The following is a description of a gene set: Catalysis of the reaction: acetyl-CoA + histone H3 = CoA + acetyl-histone H3. species: Homo sapiens Human Gene Set: GOMF_HISTONE_H3_ACETYLTRANSFERASE_ACTIVITY, and this is the list of marker genes: EP300, BRPF3, KAT6A, BRCA2, MCM3AP (minichromosome maintenance complex component 3 associated protein), MEAF6, KAT6B, JADE2, JADE1, KAT2B, BRD1, KAT7, GTF3C4, CREBBP, ING4, KAT2A